The following is a description of a gene set: Mouse Gene Set: GOBP_FUCOSYLATION The covalent attachment of a fucosyl group to an acceptor molecule. studied in species Mus musculus, and this is the list of marker genes: Fut9, Pofut2, Fut4, Pofut1, B3glct, Fut10, Fut2, Fut8, Fuom, Fut11, Sec1, Fut7, Slc35c2, Fut1